Given this list of marker genes RCC2, AP1AR, ITGB1BP1, CORO1C, EFNA5, POSTN (NCBI Gene Id 10631), FBLN1, MELTF, GBP1, DMTN, TACSTD2, SPRY4, KANK1, ACTN4, here is a description of the gene set: Human Gene Set: GOBP_NEGATIVE_REGULATION_OF_SUBSTRATE_ADHESION_DEPENDENT_CELL_SPREADING studied in species Homo sapiens Any process that stops, prevents or reduces the frequency, rate or extent of substrate adhesion-dependent cell spreading.